Given this list of marker genes Morf4l2, Psmb2, Zmiz2, Cyba, Tomm5, Kdm2b, Tnfrsf25 (tumor necrosis factor receptor superfamily, member 25), Cxcl9, Ruvbl1, Mrpl17, Dbnl (drebrin-like), Hnrnpa3, Lsm7, Psmc5, Gpatch4, Eef1g, Gbp6, Eif3i, Prmt1, Pcca, Psmd6, Canx, Stat1, Pnp, Hint1, Trp53, Grwd1 (glutamate-rich WD repeat containing 1), Hnrnpab, Igtp, Ndufa12, Psma2, Cct5, Jak2, Psmc2, Mpc1, Tfg, U2af1, Psmb5 (proteasome (prosome, macropain) subunit, beta type 5), Cxcl10, Socs1, Pdia6, Irgm1 (NCBI Gene Id 15944), Bax, Uqcrq, G3bp1, Ccdc124, Blk (B lymphoid kinase), Psma5, Eif5b, Ndufb7, Parp14, Krtcap2, Hdgf, Ran, Ier5, Txn2, Fubp1, Asb2 (NCBI Gene Id 80538), Ssb, Erh, Birc3, Llph, Mta2, H2-K1, Srsf7, Cd83, Eef1e1, Tmed2, Fkbp2, Irf8, Srsf6, Eif4g1, Ltv1, Psme1, Ebna1bp2, Nap1l1, Nudc, Psmd11, Cox5b, Pak1ip1, Rilpl2, Mrps34, Nfkbie, Tuba1b, Hsp90b1, Eif3d, Bloc1s2, Ola1, Parp9, Pus7 (pseudouridylate synthase 7), Srsf2, Tank, Tomm40, Naga, Dimt1, Stip1, Ikbke, Cdv3, Cnbp, Ppia, Eif3b, Psmd1, Gbp3, Rtp4, Sp110 (NCBI Gene Id 78814), Cxcr6, Sumo2, Serpina3f, Bccip, Akr1b1, Mrto4, Tnip1, Apex1, Pou2f2, Glrx5, Nop56, Tgtp1, Kdelr2, Mak16, Naa20, Polr2h, Il2ra, Serpina3g (NCBI Gene Id 20715), Cdc37, Rrp1b, Wdr18, Lap3, Nfkbib, Cct8, Chchd2 (coiled-coil-helix-coiled-coil-helix domain containing 2), Ccrl2, Med11, Snrpf, Timm8a1, Nol11, Tor2a, Pomp, Cct3, Mydgf, Uqcc2, Selenos, Stx11, Mrps28, Nudcd2, Slc25a5, Pebp1, Pdia4, Ncbp2, Eif1a, Pim2, H2-D1, Idnk, Mybbp1a (NCBI Gene Id 18432), Timm17a, Spcs1, Txn1, Ndufaf8, Notch1, Eif1ax, Atp5f1b, Hprt1 (hypoxanthine phosphoribosyltransferase 1), Tkt, Ogfr, Tmem14c, Anp32b, Dkc1 (dyskeratosis congenita 1, dyskerin), Tmed5, Tcp1, Eny2, Pa2g4, Edf1, Il12rb1, Gbp2, Sting1, Rcc2, Phb1, Nol8, Irf5, Phb2, Hspa8, Nsun2, Slc35b1, Gsto1, Sec61b, Plaat3, Gtpbp4, Mettl1, Grap, Xaf1, Xbp1, Cacybp, Sdf2l1, Lgals3bp, Mdn1 (midasin AAA ATPase 1), Wdr77, H2aj, Ndufaf4, Ndufab1, Il27ra (interleukin 27 receptor, alpha), Cox7b, Mrpl36, Npm3, H2-T22 (NCBI Gene Id 15051), Mycbp2, Irf1, Isg20, Nop58, Cops6, Nhp2, Rbm8a, Ssbp2, Bcl2a1b, Dnaja2, Gar1, Tap2, Cycs, Gnl3, Nop16, Psmb9, Nfkb1, Farsa, Tmem176b, Atic (5-aminoimidazole-4-carboxamide ribonucleotide formyltransferase/IMP cyclohydrolase), Trmt1, Ifit3, Sec13, Nars1, Eif3a, Ddx39a, Nlrc5, Psmc4, Ly6e, Hspa5, Wdr43, Spcs2, Pgam1, Set, Psmg4, Mrps18b, Gbp7, Lsm2, Timm17b, Pno1, Srm, Nop10, Bsg, Herc6, Cyc1 (NCBI Gene Id 66445), Zmat2, Mif, Cetn3, Manf, Rpn1 (ribophorin I), Eif2s1, Tpi1, Alg5, Tmbim6, Ssr4, Bcl3, Hsp90aa1, Mtap, Psmb10, Calhm6, Txnl1 (NCBI Gene Id 53382), Eif2s2, Zfhx2, Rpn2, Cct2, Pxdc1, Stat3, Ctss, Tap1, Ranbp1, Hmgn3, Lta, Prr29, Nampt, Nfkb2, Chchd1, Cox5a, Psmb8, Hsp90ab1 (heat shock protein 90 alpha (cytosolic), class B member 1), Tbl1x, Uchl3, Rars1, Mndal, Impdh2, Nolc1, Lsm6, M6pr, Znrd2, Sec61a1 (NCBI Gene Id 53976), Fbl, Rsl24d1, Pcbp1, Eif5a, Sec61g, Banf1, Aen, Phyh, Snrpd3, Parp10, Ndufb4 (NCBI Gene Id 68442), Gbp5 (guanylate binding protein 5), Snrpa, Npm1, Lyar (NCBI Gene Id 17089), Ms4a4c, Irf2, Ddx21, Lsm12, Ppib (NCBI Gene Id 19035), Prpf19, Eif3c, Ifit1, Rce1, Phgdh, Eif4a1, Ddx1, Ldha, Sdc4, Smox (spermine oxidase), Tyk2, St13, Strap, Rsl1d1, Tubb4b, Il18bp, Ifi203, Ltb, Gbp9, Tbrg1, Tapbpl, Stx6, Cd52 (NCBI Gene Id 23833), Rexo2, Cish, Calr, Rnf213, Mrpl20, Lpcat1, Batf, Larp1, Snu13, Mvp, Relb, Cd72, Adam8, B2m (NCBI Gene Id 12010), Psma7, Iigp1, Fkbp4, Bola2, Timm9, Rrp9, Pmepa1, Surf4, Hspd1, Pgk1, Zbp1, Dad1, Dtx3l, Dctpp1, Ndufa5, Psmb4, Tmed9, Herpud1, Ybx3, Zfp706, Uqcrb, Bst2, Cd82, Fdps (farnesyl diphosphate synthetase), Dnajb11, Timm10, Ftsj3, Phip, Aprt, Sms, Atp2a2, Nmi, Dnajc3, Atp5mc1, Ifi47 (interferon gamma inducible protein 47), Adh5, Mrpl21, Atp5mc3, Gpx1, Magt1, Ppan, Hnrnpd, Apobec3, H3f3a, Mrps7, Pdia3, Tgtp2, St6galnac4, Psmb7, Psmd7, Rrp15, Wars1, Jpt1, Prdx1 (NCBI Gene Id 18477), Exosc5, Tmem147, Nifk, Tapbp, Tmed10, Lman2, Ccdc86, Psma4, Ppp1r14b, Aldoa, Fam162a, Snrpa1, Psme2, Serp1, Ostc, Mthfd2, Ndufb6, Atp5pb, Creb1, Dtymk, Glrx, Ssr2, Irgm2, Gadd45b, Tmem154, Ncoa7, Hspa9, H2-Q7, Hspe1, Nip7, Serbp1, Gbp4, Samhd1, Clptm1l, Tmem176a, Furin, Atp5f1d, Ppa1, Ybx1, Ndufa11, Eif3g, Bysl, Ehd3, Gbp8, Ncl, Odc1, Rbm3, Mat2a, Isg15, Snrpd1, Sdhaf1, Rrs1, Polr2f, Pon2, Psma3 (proteasome subunit alpha 3), Ptma, Gspt1, Psmb6, Erap1, Mrpl12, Timm13, Nme1, Pdcd1lg2, Ly6a, Ffar2 (free fatty acid receptor 2), Ube2l3, Hnrnpdl, Prpf31, Cct7, Rala, Cd274, Emc6, Snrpd2, Ergic2, Sar1a, Scfd1, P4hb, H2-T23, Sec11c, Nfkbia, C1qbp, Alkbh1, Icam1, here is a description of the gene set: Cytokines mediate cell-cell communication in the immune system and represent important therapeutic targets. A myriad of studies have highlighted their central role in immune function, yet we lack a global view of the cellular responses of each immune cell type to each cytokine. To address this gap, the authors created the Immune Dictionary, a compendium of single-cell transcriptomic profiles of more than 17 immune cell types in response to each of 86 cytokines (>1,400 cytokine-cell type combinations) in mouse lymph nodes in vivo. A cytokine-centric view of the dictionary revealed that most cytokines induce highly cell-type-specific responses. For example, the inflammatory cytokine interleukin-1β induces distinct gene programmes in almost every cell type. A cell-type-centric view of the dictionary identified more than 66 cytokine-driven cellular polarization states across immune cell types, including previously uncharacterized states such as an interleukin-18-induced polyfunctional natural killer cell state. species: Mus musculus Genes positively differentially expressed in cell type: γδ T cell upon treatment with cytokine: IL-18 in mouse lymph nodes in vivo. Mouse Gene Set: CUI_T_CELL_GD_IL18_RESPONSE_UP from publication Cui A, Huang T, Li S, Ma A, Pérez JL, Sander C, Keskin DB, Wu CJ, Fraenkel E, Hacohen N (PMID 38057668)